The following is a description of a gene set: from publication Usher MG, Duan SZ, Ivaschenko CY, Frieler RA, Berger S, Schütz G, Lumeng CN, Mortensen RM (PMID 20697155) Inappropriate excess of the steroid hormone aldosterone, which is a mineralocorticoid receptor (MR) agonist, is associated with increased inflammation and risk of cardiovascular disease. MR antagonists are cardioprotective and antiinflammatory in vivo, and evidence suggests that they mediate these effects in part by aldosterone- independent mechanisms. We used affymetrix to characterize the effect of Mineralocorticoid Receptor deletion on macrophage transcriptional profile, and identify its requirement in normal glucocorticoid signalling. Human Gene Set: GSE23308_WT_VS_MINERALCORTICOID_REC_KO_MACROPHAGE_DN Genes down-regulated in macrophages: wildtype versus NR3C2 knockout. species: Homo sapiens, and this is the list of marker genes: SMAD2, DLD, ASNS (asparagine synthetase (glutamine-hydrolyzing)), PSRC1, ADRM1, OPN1LW, TFAP2A, NFKBIL1, SNX18, GTF2F1, CCL24, TOMM70, PHTF2, DENR, CCDC71L, ERN1, HELZ2, ZDHHC6, GPR84, SAP30, SLC23A3, SCHIP1, EPHA4, SSR3, FOXD2, CPA2, FPR1, SYK, MOB1A, LIPG, CD274, CXCL10, UBE2E2, CHUK, VASP, NFKBIZ, XRN1, PIM1, IER2, MECR, HCK, TSC22D1, HLA-DOA, MAFF, SLCO3A1 (solute carrier organic anion transporter family member 3A1), MRPL39, TPBG, SLC7A11, FOXQ1 (NCBI Gene Id 94234), IL17RD, NME6, EFS, PTBP1, SP110, PLEKHO2, C19orf12, DHX15, SPRED1, GAS1, MAGOHB, IKBKE, ZNFX1, GBGT1 (globoside alpha-1,3-N-acetylgalactosaminyltransferase 1 (FORS blood group)), TLR6, EPS15L1, MYO10, USB1, DUSP2, TWIST2, JARID2 (NCBI Gene Id 3720), SPINT2, SLC4A7 (solute carrier family 4 member 7), DAXX, MMD, FGR, RPS6KA4, CD83, ACSL4, MSN, ILRUN, PRSS44P, MED1, PFKL, ETF1, IL1B (interleukin 1 beta), NFE2L2, RCN1, UBE2N, MSC, GNG12, PHLDA1, RNF14, BLOC1S4 (biogenesis of lysosomal organelles complex 1 subunit 4), TREH, DYNC1H1, HOPX, JUNB, EIF2S2, SOD2, CEMIP2, C3orf38, ACY3, SLC30A6, SLC6A3, RNF4, SEC24B, RNF114 (NCBI Gene Id 55905), GPR85, SRSF6 (serine and arginine rich splicing factor 6), CA13, PIM2, PPM1B, CCL2, TPGS2, CCL22, CRK, LYN, IFIH1, KISS1R, PIK3CG, AIM2, TMEM68, ADPRH, ADORA2B, NEUROG1, NT5C3A, PHGDH, SURF4 (NCBI Gene Id 6836), SLC16A3, HOOK2 (hook microtubule tethering protein 2), FABP3, SEZ6, CAV1, DNAJA1, AQP2, ABCC5, GRAMD1A, GBP7, TTC1, TMEM135, WDR1, PHLDB1, TSHZ1, SCT, BIRC3, NOTCH4, CCT6A, SLC13A1 (NCBI Gene Id 6561), RND3, TMCO6, ERBB2, ENTPD2, UTP3, PSMD14, ASAH2, NUDT13, TNFAIP3, CH25H, EBI3, RBPMS2, DLL3, RAP1GDS1 (NCBI Gene Id 5910), PTGIR, TNFSF4, CASP4, FAM32A, PARP9, MORC3, MTDH, OLR1, SGMS1, SHH, CCL4, NRCAM, STAU2 (staufen double-stranded RNA binding protein 2), RNF19B, SGO1, ACTR1A, TXK, TRAF3IP2, ABCB9, JDP2, CARMIL1, GJA1, GSR, TRIM21, HEATR6, CCNL2, LDLR, SLC11A2, ACSL1, SLC26A4, ITGA4, SF1, GARS1, MMP13, MAPKAPK2, PFKP, TFEC, TMEM128